The following is a description of a gene set: studied in species Homo sapiens Human Gene Set: HP_FOCAL_SENSORY_SEIZURE Focal sensory seizure A focal sensory seizure is a type seizure beginning with a subjective sensation., and this is the list of marker genes: PRRT2, ADGRG1, MICAL1, GAL, EPM2A, ATP1A2, RELN, CNTN2, PI4KA, SCN1A, TREX1, PCDH19, CACNA1A, NHLRC1 (NHL repeat containing E3 ubiquitin protein ligase 1), LGI1, SRPX2, KCNA1